Given this list of marker genes Pth2r, Glp1r, Gng10, Gngt1, Adm2, Pth1r, Gng5, Gngt2, Gng7, Gipr, Ucn, Cd55, Adcyap1, Ucn2, Adm, Crhr2, Ghrh, Gnb3, Gng11, Vipr2, Vipr1, Sctr, Crhbp, Ucn3, Gcgr, Gip (gastric inhibitory polypeptide), Gng4, Crhr1, Sct, Pth2, Glp2r, Gcg, Ramp3, Gnb2, Gng8, Gng3, Vip, Gnb5, Adgre5 (NCBI Gene Id 26364), Iapp, Ghrhr, here is a description of the gene set: This event has been computationally inferred from an event that has been demonstrated in another species.<p>The inference is based on the homology mapping from PANTHER. Briefly, reactions for which all involved PhysicalEntities (in input, output and catalyst) have a mapped orthologue/paralogue (for complexes at least 75% of components must have a mapping) are inferred to the other species. electronically inferred by orthology from the curated human pathway part of: GPCR ligand binding species: Mus musculus Reactome Pathway: Class B/2 (Secretin family receptors)